Given this list of marker genes Igfals, Hmgcr, Eeig1, Usp15, Tsr1, Azin2, Tspan18, Srsf7, Uvssa, Synpo, Glt1d1, Trim12a, Fads1, Pitx3, Myo1g, Wnt5b, Stra6l, Ntrk2, Mc1r (NCBI Gene Id 17199), Acvrl1, Gprin1, Snx17, Sdc3, Anapc5, Samd14, Tfap2b, Lmod1, Crispld1, Cog5, Gspt1, Apmap, Prdm16, Slc12a5, Adcy1, Chd9, Rrp7a, Csrp1, Cpxm2, Cd34, Shisal1, Slc4a1ap, Mbnl1, Rnf157, Tbc1d1, Ctu2 (cytosolic thiouridylase subunit 2), Sftpd, Il31ra, Ccnf, Sox13, Ttyh2, Vmn1r63 (NCBI Gene Id 81017), Trim59, Lzts3, Adcyap1, Edem3, Ralbp1, Pcnx3, Chi3l1, Sema3b, Eif5a, Rtraf, Calcoco2, Chmp7, Elmo2, Ahrr, Serinc1 (serine incorporator 1), Mpzl3, Dop1b, Sh3bp1, Wbp1l, Amer1 (APC membrane recruitment 1), Gatad2a, Ldah, Ift56, Mlst8, Igf1r (insulin-like growth factor I receptor), Bcl2l2, Dcx, Mpped1, Cacnb3, Epha4, Otog, Rfx5, Kmt2a, Pdzk1ip1, Cxcl12, Tmie, Gprc5a, Grn, Golm2, Fchsd2, Paqr4, Dstn, Rbpj, Dnase1l2, 2810459M11Rik, Onecut2, Ar, Tap2, Cd33, Tulp4, Klhl24, Ank1, Nkiras2, Ctdsp1, Grm2, Cmtr1, Mmp17, Cldn9, Psd3, Slc2a6, Gdf6, here is a description of the gene set: Mouse Gene Set: MIR_3113_3P from publication Chen Y, Wang X (PMID 31504780) Genes predicted to be targets of miRBase v22 microRNA mmu_miR_3113_3p in miRDB v6.0 with MirTarget v4 prediction scores > 80 (high confidence targets). species: Mus musculus